Given this list of marker genes Abcd2, Srebf1, Hnf4a, Insig2, Klhl25, Eif6, Apoc2l, Dcaf5, Wdtc1, Trib3, Acadl, Pibf1, Apoa5, Anxa1, Pdk4, Nr1h2, Erlin1, Agt, Mapk9, Ptgs2, Kat2b, Mid1ip1, Apoc1, Insig1, Nr1h3, Pla2g3, Lpgat1, Rgn, Mlxipl, Il1b, Apoc2, Acadvl, Pla2g4a, Ceacam1, Brca1, Sirt1, Avpr1a, Ubr4, Slc45a3 (solute carrier family 45, member 3), Apoa4, Erlin2, Cyp7a1, Cd74, Gip, Sirt2, Apoc3, Scap, Fabp5, Ceacam2, Avp, Elovl5, Abcd1, here is a description of the gene set: Any process that modulates the frequency, rate or extent of the chemical reactions and pathways resulting in the formation of fatty acids, any of the aliphatic monocarboxylic acids that can be liberated by hydrolysis from naturally occurring fats and oils. Mouse Gene Set: GOBP_REGULATION_OF_FATTY_ACID_BIOSYNTHETIC_PROCESS studied in species Mus musculus